Given this list of marker genes Tbc1d1, Ffar4, Crhr2, Kcnj6, Pde3b, Srebf1, Cry1, Mup3, Gnao1, Fkbp1b, Ptger3, Adora1, Ptpn11, Pparg, Ndufaf2, Ptprv, Ptpmt1, Npy1r, Ucn2, Irs1, Mup1, Ppp3ca, Map4k4, Pde4c, Mup5, Sytl4, Kcnk9, Edn1, Hmgcr, Nucb2, Eny2 (NCBI Gene Id 72036), Oprm1, Crhbp (corticotropin releasing hormone binding protein), Pfkl, Vsnl1, Sfrp1, Nos1, Gja1, Pim3, Ffar2, Inha (inhibin alpha), Abcc8, Fgf23, Npvf (NCBI Gene Id 60531), Gnai1, Jagn1, Sirt1, F2rl1, Psmd9, Ucn, Il1b (NCBI Gene Id 16176), Cry2, Crh, Drd2, Il6, Stxbp5l, Osm (oncostatin M), Il11 (interleukin 11), Edn2, Rab11fip1, Rab11fip3, Fam3d, Nrg1, Pde1c, Adipoq, Gnaz, Ghrl, Rab11fip5, Inhbb, Ffar3, Rptor, Lep, Mup4, Nmb, Cartpt, Fbn1, Foxo1, Mtnr1b, Kcnq1, Uts2, Lif, Midn, Kcnj11, Anxa5, Pde8b, Hadh, Adra2a, Ucp2, Acvr1c, Madd, Rest, Chga, Tacr2, Npff, Kalrn, Kcnb1, Ghsr, Mup11, Mup2, Igfbp3, Klf7, Oprk1, Tspo, Ccn3, Prkn, Mtnr1a, Sirt4, Edn3, here is a description of the gene set: Mouse Gene Set: GOBP_NEGATIVE_REGULATION_OF_HORMONE_SECRETION studied in species Mus musculus Any process that stops, prevents, or reduces the frequency, rate or extent of the regulated release of a hormone from a cell.